Given this list of marker genes CA2, SOX4, GPR171, SALL2, TP53BP1, NCAPG2, KHDRBS3, DNAI4, PTGFRN, SYCE2, RFC3, ALYREF, SPC25, PTPRS, RAB10, IFI27L2, DHFR, KNTC1, AKAP1, RTN3, CHL1, NETO2, ALDH2, RSAD2, AOPEP, RUNDC3A, CENPS, RRM2, TMIE, NR4A1, DCLRE1A, TACC2, ATP9A, NDC80, ABI2, TK1, TRAFD1, PRR11, EZH2, TUBA4A, PUS10, MCM8, ST3GAL1, CHEK1, NIM1K, ASF1B, PPM1B, HSPA4L, GNB4, CBFB, CKS1B, MAP2, ZUP1, GMNN, CACNG4, H2AZ1, CLSPN, BRCA2, DNMT3A, CKS2, JAZF1, N4BP2, GTF2IRD1, ARMCX6, RAD54L, POP1, ENTPD7, DMRT1, POLE, MELK, CDC6, PARD6G, RAPH1, E2F1, MCM4, KLC3, CDK1, NCOA7, FAM110B, TRIP13, ISG20, SMPD4, WEE1, PLXND1, PLOD2, TLE3, MAD2L1, MXD1, IFI44, TRAF4, SMOX, MMS22L, TOR1AIP2, MCM5 (minichromosome maintenance complex component 5), IFIH1, FAR1, CUX1, KLF12, VIM, ALMS1 (ALMS1 centrosome and basal body associated protein), TFRC, RRAGD, MX1, DNTT, ADCY6, TUBB3, YPEL2, IFIT1B (NCBI Gene Id 439996), DHX58, STAT5A, CKAP2L, PURG (purine rich element binding protein G), CDCA5, EGR2, FABP5 (NCBI Gene Id 92424), OIP5, BCL3, CENPW, PTGIR, PLEKHO1, SLC25A38, CENPP, BASP1, TMEM64, LXN, IL21, LRR1, RGCC, HELLS, MX2, MSN, BLM, CDK2, PSTPIP2, CD7, CDCA8, FAP, CNOT11 (NCBI Gene Id 55571), CCR9, IFI44L, ZNF821, TBC1D19 (TBC1 domain family member 19), LMF1, MCM10, PML, UBE4B, SPSB1, CENPM, NELFE, TSC22D1, PCLAF, TUBB, MFSD10, RTP4, PAK1, RWDD4, NCMAP (non-compact myelin associated protein), RFC4, EIF2AK2, BIRC5, PCNA, LITAF, HNRNPD, CTSW, ARMCX1 (armadillo repeat containing X-linked 1), SHCBP1, CENPK, PARP9, RASL11B, ATAD5, RFC2, EPHB6, TSPOAP1, EXO1, DSCC1, RNF213, OAS2 (2'-5'-oligoadenylate synthetase 2), NDRG1, ADISSP, SLC2A9, EIF4E3, TCF19, TRIM25, FAM168A, GSK3B, LIG1, CAPG, GTF3C1, GPRASP2, LMNA, AKR1C3, CKB, ECT2, TOP2A, ZCCHC12, E2F3, SMC2, ZWILCH (zwilch kinetochore protein), ADGRG3, LHX2, here is a description of the gene set: Type 1 IFNs can conditionally activate all of the signal transducers and activators of transcription molecules (STATs), including STAT4. The best-characterized signaling pathways use STAT1, however, and type 1 IFN inhibition of cell proliferation is STAT1 dependent. We report that type 1 IFNs can basally stimulate STAT1- and STAT4- dependent effects in CD8 T cells, but that CD8 T cells responding to infections of mice with lymphocytic choriomenigitis virus have elevated STAT4 and lower STAT1 expression with significant consequences for modifying the effects of type 1 IFN exposure. The phenotype was associated with preferential type 1 IFN activation of STAT4 as compared to STAT1. Stimulation through the TCR induced elevated STAT4 expression, and STAT4 was required for peak expansion of antigen-specific CD8 T cells, low STAT1 levels, and resistance to type 1 IFN-mediated inhibition of proliferation. Thus, a mechanism is discovered for regulating the consequences of type 1 IFN exposure in CD8 T cells, with STAT4 acting as a key molecule in driving optimal antigen-specific responses and overcoming STAT1-dependent inhibition of proliferation. Human Gene Set: GSE40666_WT_VS_STAT1_KO_CD8_TCELL_WITH_IFNA_STIM_90MIN_DN Genes down-regulated in CD8 T cells treated by interferon alpha: STAT1 knockout versus STAT4. from publication Gil MP, Ploquin MJ, Watford WT, Lee SH, Kim K, Wang X, Kanno Y, O'Shea JJ, Biron CA (PMID 22968462) studied in species Homo sapiens